The following is a description of a gene set: studied in species Homo sapiens part of: Metabolism Reactome Pathway: Cytosolic iron-sulfur cluster assembly Iron-sulfur clusters containing 4 atoms of iron and 4 atoms of sulfur (4Fe-4S clusters) are assembled in the cytosol on a heterotetrameric scaffold composed of NUBP2 and NUBP1 subunits. The sources of iron and sulfur are uncertain but the process requires a sulfur-containing compound exported from mitochondria via ABCB7 (ABC7). Newly synthesized 4Fe-4S are transferred to apoproteins such as XPD and POLD1 via the CIA targeting complex, composed of NARFL, CIAO1, FAM96B, and MMS19., and this is the list of marker genes: MMS19 (NCBI Gene Id 64210), NUBP2, NDOR1, CIAO2B, ERCC2, BRIP1, POLD1, CIAO3, ABCB7, NUBP1, CIAPIN1, RTEL1, CIAO1